Given this list of marker genes IL6ST, IRF5, CARD9, IL17F, MVK, KRT1, PIK3CD, SREBF1, CORO1A, KCNN4, CEACAM6, CD3G (NCBI Gene Id 917, CD3 gamma subunit of T-cell receptor complex), STX1A, IL17RC, POU2AF1, TRAC, RAG1, TLR8, TFRC, DCLRE1C, CLCA4, LCK, ZAP70, EDNRA, TRAF3IP2 (TRAF3 interacting protein 2), SLC39A4, GSTM3 (NCBI Gene Id 2947), GCLC, ADA, GATA2, STAT1, STK4 (serine/threonine kinase 4), RORC, SLC11A1, CFTR, TYK2, ARPC5, ATRX, SLC6A14 (solute carrier family 6 member 14), CD3D, CD40LG, SPIB, IL12RB1, PDCD1, JAK3, RAG2, IL2RA, IL2RG, PLCG2, PGM3, IKBKB, BRAF, CYBC1, NCF2, HFE, SLC9A3, TNPO3, SERPINA1, SP110, TP53, STAT3, CARMIL2, C1QB, RNF31, SDR9C7, IL17RA, CTLA4, GJB6, MMEL1, ATR, NFKBIA, AIRE, HMOX1, ITGB2, KNSTRN, SLC26A9, IL7R, FOXN1, DOCK2, USP48, CARD11, IKBKG, GJB2, WDR1, ZNF341 (NCBI Gene Id 84905), CYBA, NCF1, CD247, HPGD, IKZF1, RFXAP, ZBTB24, CLEC7A, AP3B1, CEACAM3, EPG5 (ectopic P-granules 5 autophagy tethering factor), CD3E, IRF1, CIITA, TGFB1 (NCBI Gene Id 7040), CDH23, MIF, CYBB, DCTN4, TNFSF15, BTD, USP8, MAP3K14, NFKB2, IL21R, RFXANK (regulatory factor X associated ankyrin containing protein), IL12A, NR3C1, DOCK8, RFX5, DEF6, PSMB10, here is a description of the gene set: studied in species Homo sapiens An unusual fungal infection that is regarded as a sign of a pathological susceptibility to infection by a fungal agent. Human Gene Set: HP_UNUSUAL_FUNGAL_INFECTION Unusual fungal infection